Given this list of marker genes NUS1, DHDDS, here is a description of the gene set: studied in species Homo sapiens part of: Diseases associated with glycosylation precursor biosynthesis Reactome Pathway: Defective DHDDS causes RP59 The ER membrane-associated enzyme dehydrodolichyl diphosphate synthase (DHDDS) normally mediates the sequential head-to-tail cis addition of multiple isopentyl pyrophosphate (IPP) molecules to farnesyl pyrophosphate (E,E-FPP) to produce polyprenol pyrophosphate (pPPP). Dolichol in humans contain homologues ranging from 17-23 isoprene units, the most common homologues contain 19 or 20 isoprene units. Dolichol is an important substrate in the N-glycosylation of proteins, including rhodopsin.<br><br>Defects in DHDDS cause retinitis pigmentosa 59 (RP59; MIM:613861), a pigment retinopathy, characterised by retinal pigment deposits (visible on fundus examination) and primary loss of rod photoreceptors followed by secondary loss of cone photoreceptors. Sufferers typically have night vision blindness and loss of mid to peripheral vision. As the condition progresses, they lose far peripheral vision and eventually central vision.